Given this list of marker genes RDH5, KLHL36 (NCBI Gene Id 79786), CCND1, MAMDC4, HOOK1, SLC25A23, MAT1A, PHF13, CYP2C8, TRIB3, NADK, RPL3, EPHX2, MARCHF6, GLRX5, FST, SARAF (NCBI Gene Id 95251), LHPP, ID2, KRT8, PRNP, HBA1, KDM8, ANPEP, PZP, AQP12A, JMJD8, PLEK2 (NCBI Gene Id 26499), MACROD1, GSE1, IDH2, DCPS, CNNM3, KIF13B, SDHB, F7, MT2A, IER3, RACK1, TERF2IP, CXCL16, CDK9, ZFPM1, LRRC28, ATOH8, ATP5F1A, LAMP1, TP53INP1, MAP7, APOF, PEX11G, PRKAG2, PGM2, ASCL1, GJB1, PPP1R13B, IGF2, GPAT3, GLUD1, F12, MYOM2 (myomesin 2), MRPL53, PON1, FUCA1, RPUSD4, GNPTG, FTCD, CHST7, UBE2J1, PWWP3A, FN3KRP, SLC6A12, NUCB1, ZNF395, AKR7A3, SPP2, BGN, SERPINF1, KMO, GOT2, MXRA5, SLC39A14, SELENOO, RGL1, NRDE2, PPP1R15A, SLC20A1 (solute carrier family 20 member 1), NAP1L4, ACOT12, PRODH2, FERMT2, TMPRSS6, EGR1, MFN2, LDLR, CYP4A11, TNFRSF1A, CMBL, TAF6L, PHLDA1, TSPAN9, APLP2, SFXN5, ACOX3, FHIP1B (NCBI Gene Id 84067), KNG1, LINC01554, TOLLIP, MPND, TRIB1, WDR72, NAT2, SGPP1, PLEKHG3, ENO1, PPFIBP2, ZCCHC14 (zinc finger CCHC-type containing 14), SNAPC4, SERBP1, SLC25A10, ACCS, SLC2A2, IGFBP4, GRAMD2B, TNFRSF1B, ZBTB48, DNAJA1, SERPINA6, ASPDH, IDNK, ADI1, PMPCA, HGFAC, AIG1, ENTPD5, NCOA4, ALPL, FOS, SERTAD1, ALDH2, BHLHE40, SLC7A5, NR4A2, TCIM, RPL12, SIRPA, L2HGDH, TMEM256, ADIPOR2, PLIN2, CRP, TMEM97, REEP6, ACAT2, LYRM1, CSRNP1, ATF5, POLE, GNA11, MPC1, TRAPPC2L, CCDC28A, URGCP, FBP1, VPS37B, KLKB1, LECT2, CCN1, INSIG2, PINK1, DYNC1LI2, SIDT2 (SID1 transmembrane family member 2), APOA1, PHKA2, FUOM, PHGDH, APLNR, IRF8, NDUFB8, COL6A1, SECISBP2L, EZR, SELENOW, C1orf162, ACAT1, CXXC5, NCLN, DGAT1, TPT1, SRF, CYP4F22, SLC10A1, AGMO, RCL1, GTF2E2, CYP3A43, CAMK1, OAT, MTFR1L, RETSAT, DUSP5, STAB1, AGPAT2, SLC13A5, ACAD11, DCUN1D3, DGAT2, MSRA, GATM, SOD1, THOP1, ARL6IP1, WFS1, EEF2, STK11, CACNA1H, ANKRD46, HDHD2, ORM1, BCL2L13, ENO3, LCAT, RXRA, APOB, ARNT, LY6E, SLC22A1, CYP2E1, PSMC1, ATXN2, VTA1, FKBP4, ESR1, EXOSC6, STAP2, SCD, TBL1X, TRIM44, SFXN1 (NCBI Gene Id 94081), DNMT3L, PLOD1 (NCBI Gene Id 5351), CPED1, SMIM14, OGDHL, SLC25A11, CERS6, IRX1, TGDS, TKFC, FAAH, FASN, SAP18, MAPRE2, ATP6V1B2, ZSWIM8, PLA2G2A, PCNX1, TUBGCP2, PPP2R2A, NUDT14, SHMT1, IGFALS, BCO2, IFNAR1, NOCT, ARMC6, THRSP, CAPN6, NEK6, NNMT, MT1A, ACAA1, NDRG2, SLC8B1, DCAF8, INMT, F8A1, ZG16, HAMP, MRPS2 (NCBI Gene Id 64972), PTMS, LDHA, HAPLN4, MYO10, HEBP2, RND3, FAM32A, VAV2, SLC25A47, NTHL1, MPDU1, FGA, RELN, SAA4, NFKBIA, IRF1, SDHAF2, PTH1R, FURIN, HADH, LPCAT3, HSD3B7, ADH1A (NCBI Gene Id 124), LTBR, RAP1GAP, UBALD1, THOC2, ITIH2, GPD1, ELP3, ANKRD33, TPRG1L, VARS2, C9 (NCBI Gene Id 12279), ENKD1, TPCN2, FMO3, ATG101, ZNF330, AGXT2, ACADSB, EVL, ADH4, IGF2R, TRAPPC6A, ADM, TRIP6, MT1X, MT1M, BCKDK, APOA2, SKAP1, GSDMB, GHR, HMGCL, AK3, KLF2, LONP1, CFAP410, PLG, BOK, PSMA2, PAFAH2, ETS2, SHFL, SRSF5, SERPINF2, MAN2B2, SYNJ2BP, NDFIP2, KHSRP, C1RL, TFF3, ITIH1, UBXN6, CLDN2, CNDP1, SERPINE1, CHD8, MIDEAS, MICU1, DMAP1, CLUH, ALKBH3, PCBP2, RITA1, VTN, CERS4, TMEM86B, CFI, FOSB, CTSF, ESPN, PRG4, SHMT2, RAB26, MASP2, C11orf24, ARFGAP1, AGT, KIAA2013, RCN1, DHRS1, VPS26B, SCYL1, SERPINA5, ZNF180, DYNLL2, F9, PPARGC1A, ALDOB, ZBED1, IGFBP3, EIF2AK1, SEC14L4, FAHD2B, PNPLA7, RDH16, KANK4, CCL16, PDXK, GJB2, ARHGAP10, AZGP1, CALM1 (NCBI Gene Id 801), CYP1A2 (cytochrome P450 family 1 subfamily A member 2), VPS9D1, AVPI1, COX4I1, DPYS, AMBP, PCOLCE, DYNC1H1, ANGPTL3, PCYOX1, BBOX1, SRSF6, C3, INTS10, CDA, PSMB10, CSK (NCBI Gene Id 1445), NMT1, ITCH, KCNJ10, C1orf50, ANGPTL8, PAF1, ACACB, HSPA5, SRD5A1, CHMP7, TOR3A, DPT, ZFP36, HIPK2, LRP5, SHBG, UPB1, MVK, ICAM3 (intercellular adhesion molecule 3), ABHD10, C5, H3-3B, ALDH9A1, TMEM82, ZNHIT1, INHBE, MLPH, SDC4, ACADVL, ANXA10, MT1B, HOGA1, MTRF1, AGMAT, DIS3L, MT1P3, TENT5A, DIAPH1, DERA, ASGR1, CPEB3, EIF5A, CD81 (CD81 molecule), GSTP1, KYNU, ENDOG, SERPINA10, COLEC11, MT1F, SAMD4A, KAT6A, PCMT1 (protein-L-isoaspartate (D-aspartate) O-methyltransferase), GCGR, TSHZ2, SLC19A3, DECR1, DHRS7 (dehydrogenase/reductase 7), ECHS1, CTSB, PGRMC2, C1orf115, SH3BGRL2, DEFB1, RPF2, CHCHD10, HMGCR, ARG1, OAF, HDAC6, ADAMTSL2, ZDHHC14, SARS2, FITM1, ACADS, PSMF1, NDEL1, MLLT3, PLSCR4, FCN3, HSBP1, PAM16, CD99L2, TRIR, MT1G, EBPL, NOP53, CROT, TNFRSF14, CYGB, ZYG11B, JUND (NCBI Gene Id 3727), TMBIM6, FOXD4L4, RNF115, TMEM30B, CENPV, TM7SF2, CFHR3, CLDN3, PBX3, ACP2, PLPBP, NOP14, TCF25, HADHA, HMGCS1, ERLIN1, TCEA3, TTR, VNN1, CYP39A1, EPHA2, PEPD, SLC35A1, C8A, CRISPLD2, XPNPEP2, MRM3 (mitochondrial rRNA methyltransferase 3), here is a description of the gene set: Genes down-regulated in hepatocellular carcinoma (HCC) compared to normal liver samples. from publication Acevedo LG, Bieda M, Green R, Farnham PJ (PMID 18413731) There is widespread interest in efficient characterization of differences between tumor and normal samples. Here, we show an effective methodology for genome-scale characterization of tumors. Using matched normal and tumor samples from liver cancer patients, as well as non-cancer-related normal liver tissue, we first determined changes in gene expression as monitored on RNA expression arrays. We identified several hundred mRNAs that were consistently changed in the tumor samples. To characterize the mechanisms responsible for creation of the tumor-specific transcriptome, we performed chromatin immunoprecipitation on microarray experiments to assay binding of RNA polymerase II, H3me3K27, and H3me3K9 and DNA methylation in 25,000 promoter regions. These experiments identified changes in active and silenced regions of the genome in the tumor cells. Finally, we used a virtual comparative genomic hybridization method to identify copy number alterations in the tumor samples. Through comparison of RNA polymerase II binding, chromatin structure, DNA methylation, and copy number changes, we suggest that the major contributor to creation of the liver tumor transcriptome was changes in gene copy number. Human Gene Set: ACEVEDO_LIVER_CANCER_DN species: Homo sapiens